Given this list of marker genes GHSR, MIR126, MIR130A, MIR27A, MIR495, MIR135B, ITGA4, SIRT6, MDK, NRARP, ADAM17, PDPK1, MIR132, PLCG1, GHRL, HMGB1, APLN, SP1, MIR21, PROK1, AKT3, STAT3, MIR499A, FGF2, MIR29A, FGFR1, IGF2, here is a description of the gene set: species: Homo sapiens Human Gene Set: GOBP_POSITIVE_REGULATION_OF_VASCULAR_ENDOTHELIAL_CELL_PROLIFERATION Any process that activates or increases the frequency, rate or extent of vascular endothelial cell proliferation.